Given this list of marker genes SLC12A2, CLIC5, COL4A3, RHPN1, SERPINB6, PTGER4, ART3 (NCBI Gene Id 419), ADM, PDE10A, MAPT, NPHS2, IQGAP2, HSPA1A, FAM241A, H3C15, SEMA3E, RASSF10, CD55, GABRA4, SCD, SGIP1, EGF, TLR4, PTPRVP, TOP1MT, ADAMTS5, SH3BGRL2, LRRFIP1, TSPAN2, PARP4, HSPA1B, UMOD, GALC, MERTK, here is a description of the gene set: Genes most strongly down-regulated in kidney glomeruli isolated from TCF21 knockout mice. Human Gene Set: CUI_TCF21_TARGETS_DN studied in species Mus musculus from publication Cui S, Li C, Ema M, Weinstein J, Quaggin SE (PMID 16207825) Mouse mutations have provided tremendous insights into the molecular basis of renal and glomerular development. However, genes often play important roles during multiple stages of nephrogenesis, making it difficult to determine the role of a gene in a specific cell lineage such as the podocyte. Conditional gene targeting and chimeric analysis are two possible approaches to dissect the function of genes in specific cell populations. However, these are labor-intensive and costly and require the generation, validation, and analysis of additional transgenic lines. For overcoming these shortcomings and, specifically, for studying the role of gene function in developing glomeruli, a technique to isolate and purify glomeruli from murine embryos was developed. Combined with gene expression profiling, this method was used to identify differentially expressed genes in glomeruli from Pod1 knockout (KO) mice that die in the perinatal period with multiple renal defects. Glomeruli from early developing stages (late S-shape/early capillary loop) onward can be isolated successfully from wild-type and KO kidneys at 18.5 d postcoitus, and RNA can readily be obtained and used for genome-wide microarray analysis. With this approach, genes that are differently expressed between glomeruli from Pod1 KO and wild-type mice were identified, including a four-fold reduction of alpha 8 integrin mRNA in glomeruli from Pod1 KO mice that was confirmed by immunostaining. This procedure may be adapted to any transgenic strain, providing a rapid and efficient method to dissect the function of specific genes in glomerular development.